Given this list of marker genes Kif5b, Dynll1, Gria2, Ap3b2, Snapin, Gabarapl1, Ap3s1, Sod1, Bloc1s5, Uhmk1, Arl8b, Canx, Oprm1, Kif1a, Fmr1, Arl8a, Rab17 (RAB17, member RAS oncogene family), Abhd12, Armcx3, Kif17, Ada (NCBI Gene Id 11486), Dync1i1, Stau2, Nefl (NCBI Gene Id 18039), Zc3h14, Spg7, Ap3d1, Wls, Ckap5, Kif3b, Klhl17, Flot2, Hpca, Mapk1, Agbl4, Ap3m2, Hap1, Rab21, Madd, Kif21a, Dtnbp1, Agtpbp1, Rab27b, Kif1b, Kif21b, Grik2, Bloc1s4, Hnrnpab, Kif3c, Abhd13, Ap3b1, Kif5c, Lrrk2, Bsn, Bloc1s1, Bloc1s2, Kif5a, Grik3, Trim46, Hip1r, Spast, Baiap2, Kcnab1, Bloc1s6, Rangap1, Mapk8, Ap3m1, Map1a, Ranbp1, Ndel1, Kif3a, Chrna2, Hnrnpa2b1, Mapk8ip3, Dst, Uchl1, Cdkl5, Dlg4 (discs large MAGUK scaffold protein 4), Ap3s2, Hsbp1, Hif1a, Pqbp1, Hspb1, Sybu, Caly, Map2k1, Map2k4 (NCBI Gene Id 26398), Hdac6, Mgarp, Kifap3, Camk2a (NCBI Gene Id 98128), Eif4ebp2, Htt, Neto1, Bloc1s3, Tmem108, Arc, Dlg2, Pafah1b1, Map2, here is a description of the gene set: studied in species Mus musculus Mouse Gene Set: GOCC_NEURON_PROJECTION_CYTOPLASM All of the contents of a plasma membrane bounded neuron projection, excluding the plasma membrane surrounding the projection.